The following is a description of a gene set: The process in which a relatively unspecialized myeloid precursor cell acquires the specialized features of any cell of the myeloid leukocyte, megakaryocyte, thrombocyte, or erythrocyte lineages. studied in species Homo sapiens Human Gene Set: GOBP_MYELOID_CELL_DIFFERENTIATION, and this is the list of marker genes: SRP54, MIR221, ZBTB7A, TF, PRKDC, IL20, CDK6, VPS33A, TMEM64, HMGB1, FBXW7, HSPA1B, JMJD6, LTF (lactotransferrin), BMP2, PRDX3, HMGB3, GP5, THOC5, SMAP1, NF1, INHA, HMGB2, BPGM, ABCB10, THPO, TMEM14C, TLR3, B2M, GATA1, SP3, DMTN, P4HTM, VPS33B, CALCR, DNASE2, IL1RL1, IRF8, ISG15, PDE1B, TUBB1, ARNT, CARTPT, TNFSF11, TAL1, JAK2 (Janus kinase 2), UFL1, IL12B, IL34, H4C3 (H4 clustered histone 3), BLVRB, FAM3C, SCIN, MFAP2, STAT1, MYC, MT1G, ANKRD54, IFI16, H4C2, KAT6A, TRIM58, PARP1, PAF1, LYAR, IL15 (NCBI Gene Id 3600), SFRP1, ETS1, RAC2, PPP3CA, PRKCA, KCNQ1, SRC, MITF, CIB1, TMEM178A, GATA2, KLF10, HSPA9, OSTM1, C1QC, SELENOW, PRMT6, SLC4A1, GAB3 (GRB2 associated binding protein 3), LRRC17, SH3PXD2A, POU4F1, DCSTAMP, MMP9, LIF (LIF interleukin 6 family cytokine), ITGB6, LILRB4, NCAPG2, MTOR (mechanistic target of rapamycin kinase), APP, ABI1, MEIS2, NFKBIA, GLUL, ADGRF5 (adhesion G protein-coupled receptor F5), TRIM10, MIR222, CD74, RPS14, ARID4A, TREM2, TESC, CREB1, CD101, SKIC8, PRTN3, IL25, EEIG1, CEBPA, CHMP5, PTPRJ, PPARGC1B, IGSF23, LTBR, CLEC5A, ATP5IF1, HSPA1A, VEGFA, NOTCH2, KIT, CLPB, MIR223, ADAR, UBASH3B, EIF6, OCSTAMP, BBLN, EP300, PAFAH1B1, PKNOX1, WASF2, TOB2, TGFBR3, IKZF1, BATF, THRA, HCLS1, TSPO2, BATF2, H4C6, EPB42 (NCBI Gene Id 2038), TYROBP, AHSP, GATA3, HDAC6, TNF, CALCA, SLC11A2, GLO1, GPR68, MEIS1, IAPP, TCIRG1, ERFE, HNRNPU, RBPJ, AP3B1, PIK3R1, ERCC2, OSCAR, F2RL1, CD81, FBN1, FCER1G, PTPN6, L3MBTL1, KLF2, PRDM16, H4C1, CDC73, ITPKB, NAGLU, CASP3, BAP1, KLF13, JUNB, GP1BA, DHRS2, JUN, HLA-DRB1 (major histocompatibility complex, class II, DR beta 1), CCL3, TRIB1, FLNA, PDE2A, MED1, MIR125B1, ZNF385A, PTBP3, PIR, ZFP36, LEO1, HOXA9, RIPK1, DLL1, CITED2, MAFB, RNF41, NCKAP1L, STAT5A, POU4F2, PIAS3, FAM210B, LYN, H4C5, HAX1, PLA2G3, CSF1R, CDKN1C, PF4, CD109, FES, NCOA6, RAB7B, EPAS1, MPL, VPS54, LDB1, CCR1, PIK3CD, EPHA2, SH2B3, RPS19, CEBPB, EFNA2, ZFPM1, H4C15, HOXB8, GPR171, HOXA7, ATP6AP1, VPS13A, EIF2AK1, ZNF675, RHAG, TNFRSF11B, NR3C1, FLVCR1, ACVR2A, TMOD3, MIR486-1, MPIG6B, TPM4, UBD, FSHR, PTK2B, UBA5, CLDN18, FLI1, HIF1A, TIFAB, GPR137, IL5, MAPK11, FSTL3, TRAF6, CSF2, PSEN1, GP1BB, GPC3, CCL19, ARID3C, SPI1, RELB, NKAP, RCOR1, CEBPE, FOXO3, PITHD1, SFXN1, MAF, LRRK1, CTNNB1, CSF1, CCN4 (NCBI Gene Id 8840), QKI, GP9, DYRK3, PIP4K2A, BRD1, TIRAP, SLC25A40, NBEAL2, PRKX, CBFA2T3, CSF3R, SLC25A38, CDKN2B, RASSF2, PTPN11, TNFAIP6, ANXA2, ZBTB46, H4C12, FOS, SIRT1, PURB, NKX2-3, STAT3, STAT5B, CBFB, JAGN1, PTPN2, KAT7, ZNF16, TET2, FAXDC2, ADIPOQ, TLR4, HEATR3, RBM15, CLEC1B, LILRB1, PABPC4, HSF1, FSHB, SNX10, IL33, LGALS9, FARP2, RUNX1, HOXA5, GPR55, ALAS2, FAM20C, CCR7, TM4SF19 (NCBI Gene Id 116211), FOSL2, H4C16, CUL4A, LBR, MYH9, GAB2, MAPK14, GABPA, SOCS1, MIR145, MTURN, CTR9, CD4, LIPA, NRROS, UCP2, ETV2, IL23A, MFHAS1, EPO, H4C4, CNOT4, NDP, NPM1, PPARG, IFNG, ID2, IFT80, ACVR1B, CEBPG, ACIN1, RACGAP1 (NCBI Gene Id 94651), IRF4, TFE3, DIAPH3, CDIN1, SMAD5, INHBA (NCBI Gene Id 3624), RAC1, MYB, PRMT1, RPTOR, TAOK3, MB, CTNNBIP1, HIPK2, P2RX5, IREB2, ALAS1, SLC48A1, FASN, IL23R (interleukin 23 receptor), EVI2B, LARGE1, APCS, RASGRP4, BMP4, IL11, BATF3, GPR183, NEDD9, SLC4A2, RB1, BCL6, KITLG, RHEX, NEMP1, H4C9, SBNO2, TFRC, YPEL4, TLR2, LILRB3, KLF1, MYD88 (MYD88 innate immune signal transduction adaptor), H4C8, FECH, NDFIP1, SRF, HBZ, HSCB, ITGB8, SLC25A5, TGFB1, IL17A, BGLAP, INPP5D, L3MBTL3, CDC42, H4C11, G6PD, ZBTB16, JAG1, WDR1, H4C13, SIGLEC15, PRXL2A, IRF7, SLC1A5, KAT8, LEF1, SPIB, TCTA, ACTN1, CFLAR, H4C14, NFE2L1, SNRK, IL4 (NCBI Gene Id 3565), RARA, MAEA, RARG, PLA2G10, GPR137B, CSF3, IGHE, MFSD8, GBA1, HOXB7, MEF2C, CDK5RAP3, CCDC39, ZFP36L1, TNFRSF11A, IL31RA, PML, SLC9B2, CASP9, SENP1, CEACAM1, FOXP1, LOX, KMT2E, TCEA1, TSPAN2, CASP8, CAMK4, FADD, TGFBR2